Given this list of marker genes Wnt3a, Fgfr1, Fgfr2, Lrp6, Aspm, Dct, Lef1, here is a description of the gene set: studied in species Mus musculus The division of a neuroblast located in the forebrain. Neuroblast division gives rise to at least another neuroblast. Mouse Gene Set: GOBP_FOREBRAIN_NEUROBLAST_DIVISION